The following is a description of a gene set: species: Mus musculus Any process that modulates the frequency, rate or extent of response to drug. Mouse Gene Set: GOBP_REGULATION_OF_RESPONSE_TO_DRUG, and this is the list of marker genes: Sufu, Abcc1, C130074G19Rik, Ptpn5, Abcb1a, Chrna7, Pon3, Grm2